The following is a description of a gene set: from publication Karlsson G, Liu Y, Larsson J, Goumans MJ, Lee JS, Thorgeirsson SS, Ringnér M, Karlsson S (PMID 15769904) Human Gene Set: KARLSSON_TGFB1_TARGETS_UP species: Mus musculus Genes up-regulated by TGFB1 in MEF cells (embryonic fibroblast) via TGFB1R. Transforming growth factor-beta1 (TGF-beta) regulates cellular functions like proliferation, differentiation, and apoptosis. On the cell surface, TGF-beta binds to receptor complexes consisting of TGF-beta receptor type II (TbetaRII) and activin-like kinase receptor-5 (Alk5), and the downstream signaling is transduced by Smad and MAPK proteins. Recent data have shown that alternative receptor combinations aside from the classical pairing of TbetaRII/Alk5 can be relevant for TGF-beta signaling. We have screened for alternative receptors for TGF-beta and also for gene targets of TGF-beta signaling, by performing functional assays and microarray analysis in murine embryonic fibroblast (MEF) cell lines lacking Alk5. Data from TGF-beta-stimulated Alk5(-/-) cells show them to be completely unaffected by TGF-beta. Additionally, 465 downstream targets of Alk5 signaling were identified when comparing Alk5(-/-) or TGF-beta-stimulated Alk5(+/+) MEFs with unstimulated Alk5(+/+) cells. Our results demonstrate that, in MEFs, TGF-beta signals exclusively through complexes involving Alk5, and give insight to its downstream effector genes., and this is the list of marker genes: CACYBP, MYC, PPA1, SET, MRTO4, PPP1R2, SHMT2, SALL1, NAE1, ZYX, BHLHE40, TOMM20, MPHOSPH6 (M-phase phosphoprotein 6), EIF3B, IDH3A, NAA25, GTPBP4, IPO5, HSPE1, ZMIZ1, HMGA2, EEF1E1, PPRC1, TOMM70, CDK17, SLTM (NCBI Gene Id 79811), KPNB1, SLC20A1, RSL1D1, RWDD1, BMP1, ZC3H15, EIF2B3, BAZ1A, LYAR, NUAK1, PHGDH, MYBBP1A, TCP1, TNFRSF12A (TNF receptor superfamily member 12A), ACTN1, RCC1, CYP1B1, PTP4A1, DLAT, DPY19L1, ABRACL, UCHL3, PELO, CCT3, KLF6, SYNCRIP, NAA15, HSPD1, YBX3, NIN, CCN2, LMLN, EIF3A, GJB3 (NCBI Gene Id 91028), CYCS, EXT1, JADE1, LRP8, HSPA9, GTF2F2, BCAT1, ABCE1, TPM1, PUM3, TNFRSF9, CCT8, ARHGAP26, ANXA2, UTP18, WDR77, WDR75, TIMP1, MAK16, GNL3, NSUN2, NIP7, ADISSP, SRM, BTBD10, NCL, PMEPA1, GCSH, CDC34, GEMIN6, PREP, TPM4, GARS1, EIF5A, C16orf89, SLC25A5, PTK2, MSN (NCBI Gene Id 4478), DDX21, ACTR3, EIF2S1, GADD45G, NOLC1, ESD, HSPH1 (NCBI Gene Id 9835), SLC8A1, COQ10B, CD44, CHD3, EIF2S2, CTU2, CCT2, EIF4G1, USP10, BAG2, RRM2, SNX7, ZIC4, MMP14, EIF5, REPS2, RPF2 (ribosome production factor 2 homolog), MIR22HG